Given this list of marker genes Naxe, Mccc2, Nnmt, Slc5a6, Coasy, Mmachc, Mmab, Nmrk1, Qprt, Tcn2, Slc25a32, Btd, Slc52a3, Mocos, Mthfr, Slc19a1 (NCBI Gene Id 20509), Mthfd2 (NCBI Gene Id 17768), Mtrr, Nmnat3, Slc25a19, Cblif, Vnn1, Naxd (NAD(P)HX dehydratase), Pnpo, Nmrk2, Flad1, Naprt, Slc25a42, Mocs3, Gm19410, Slc25a16, Acp5, Tpk1, Pank3, Slc22a13, Cd38, Nadsyn1, Pdzd11, Slc2a1, Slc5a8, Nudt12, Folr2, Abcd4, here is a description of the gene set: Reactome Pathway: Metabolism of water-soluble vitamins and cofactors part of: Metabolism of vitamins and cofactors electronically inferred by orthology from the curated human pathway This event has been computationally inferred from an event that has been demonstrated in another species.<p>The inference is based on the homology mapping from PANTHER. Briefly, reactions for which all involved PhysicalEntities (in input, output and catalyst) have a mapped orthologue/paralogue (for complexes at least 75% of components must have a mapping) are inferred to the other species. species: Mus musculus